Given this list of marker genes SLC16A9, GSTA1, CLDN10, MIOX, PEPD, GPX3, GAL3ST1 (NCBI Gene Id 9514), CFI, PXMP2, AZGP1, CLTRN, LACTB2, AQP1, SMIM24, CUBN, APOM, GSTA2, AGT, C11orf54, RIDA, LRP2, DDC, KHK, SLC6A13, RBP5, GAMT, SLC5A12, SLC17A3, MSRA, NAT8, GLYATL1, GCHFR, AMN, ACSM2A, CDHR5, AGXT2, FOLR1, TSPAN1, CXCL14, TNFAIP6, GLYAT, ACSM2B, CES2, LGALS2, SLC22A18, PCSK1N, PRAP1, BBOX1, AOC1, PDZK1, here is a description of the gene set: Genes upregulated in subsets of cells of a given type within various tumors from publication Gavish A, Tyler M, Greenwald AC, Hoefflin R, Simkin D, Tschernichovsky R, Galili Darnell N, Somech E, Barbolin C, Antman T, Kovarsky D, Barrett T, Gonzalez Castro LN, Halder D, Chanoch-Myers R, Laffy J, Mints M, Wider A, Tal R, Spitzer A, Hara T, Raitses-Gurevich M, Stossel C, Golan T, Tirosh A, Suvà ML, Puram SV, Tirosh I (PMID 37258682) Human Gene Set: GAVISH_3CA_MALIGNANT_METAPROGRAM_38_GLUTATHIONE studied in species Homo sapiens In this study, an extensive analysis was conducted to define meta-programs (MPs) capturing intra-tumor heterogeneity across a spectrum of tumor types. The approach utilized non-negative matrix factorization (NMF) to analyze each cell type separately within individual tumor samples. This involved the analysis of malignant cells, macrophages, fibroblasts, endothelial cells, epithelial cells, T-cells, and B-cells. NMF was executed with varying parameter values (K=4, 5, 6, 7, 8, 9), thereby generating 39 programs for each cell type per sample. Each NMF program was summarized by the top genes based on NMF coefficients.\nRobust MPs were then delineated for each cell type using a set of stringent criteria, including recurrence within the same tumor, similarity to programs in other tumors, and non-redundancy within a tumor. Subsequently, these robust NMF programs were clustered (per cell type) based on Jaccard similarity, leading to the identification of MPs associated with each cell type.\nTo enhance the quality of the MPs, a refinement steps were undertaken, involving the removal of MPs suspected of reflecting low-quality data (with an overrepresentation of ribosomal proteins or mitochondrial-encoded genes), single-study inclusion, or similarity to miss-annotated cell types.